The following is a description of a gene set: A process that modulates long-term neuronal synaptic plasticity, the ability of neuronal synapses to change long-term as circumstances require. Long-term neuronal synaptic plasticity generally involves increase or decrease in actual synapse numbers. species: Mus musculus Mouse Gene Set: GOBP_REGULATION_OF_LONG_TERM_NEURONAL_SYNAPTIC_PLASTICITY, and this is the list of marker genes: Egr1, Fcgr2b, Kras, Rab11a, Grik1, Lnpep, Grin1, Rims1, Syngap1, Kit, App, Nf1, Grin2b, Grm5, Snca, Fxr1, Rab8a, Synpo, Kcnj10 (potassium inwardly-rectifying channel, subfamily J, member 10), Kdr, Drd2, Syp, Neto1, Syngr1, Fmr1, Grin2a, Neurl1a, Bdnf, Fxr2, Camk2b, Nptn, Shank3, Hras, Dlg4, Grik2, Rab5a, Ephb2, Agt, S100b